The following is a description of a gene set: from publication Ventre E, Brinza L, Schicklin S, Mafille J, Coupet CA, Marçais A, Djebali S, Jubin V, Walzer T, Marvel J (PMID 22942430) studied in species Homo sapiens Effects of IL-4 on CD8 T cells functions are largely unknown. IL-4 induces survival and proliferation of CD8 T cells, but several studies suggest that IL-4 could also affect several functions of CD8 T cells such as cytotoxicity. Our team has shown that IL-4 repress the expression of Ccl5 in vitro. To define more precisely the impact of IL-4 on CD8 T cells, we performed a whole genome expression microarray analysis of naive and memory CD8 T cells cultured in presence or absence of IL-4. This approach allowed us to define the IL4-gene-expression signature on CD8 T cells. Genes down-regulated in comparison of memory CD8 T cells versus those treated with IL4. Human Gene Set: GSE32423_CTRL_VS_IL4_MEMORY_CD8_TCELL_DN, and this is the list of marker genes: PIP5K1C, SLC35B2, PSME2, SLC12A4, PPM1E, SARS1, NDUFB10, AARS1, CCT8L2, PHLPP1, ELMO3, SLC35F1, SYT7, TPPP3, GLIS3, RAB13, NGFR, ARHGAP26, EN2, MTFR2, UBL4A, BCAP31, MRPS25, COPS6, GGACT, GBP4, BRS3, PDE6C, PRKD1, MAGEA11, C1orf56, FPR2, IRGM, NSMCE1, ARHGEF28, RIGI, PINX1, MARCHF2, WNT16, CHCHD4, IL15RA, EIPR1, NDST1, ACAT2, PPIH, NIN (NCBI Gene Id 57681), MEI1, SLC12A1, PSMF1, NPC2, SMC1A, MAP3K8, SFMBT1, CLN5, DHX58, MBNL2, FBXW12, NAGPA, RNASEK, SLC25A13, ANGPTL2, SLC16A7, VPS4A, SEC24A, FAM229B, PLEKHH1, NUBP2, TAPBP, SLC4A1AP, ETNK1, P2RX5, SNRPN, SLIRP, IKZF3, POLM, SLC7A13, NAALADL1, PRSS23, ZNHIT1, AK2, MBD6, SPRR2A, GNMT, HLA-DMA, SYCE2, CXorf58, STAT2, USP7, TRAPPC3, SSPN, PCOLCE2 (procollagen C-endopeptidase enhancer 2), UBA1, PANX1, REX1BD, LRRIQ4, IFT27, HSD17B7, BCL2, SULF2, SLC26A6, PPP3CC, TADA1, AFG2B, ADCY10, MVD, RAB19, BAK1, PARP9, DHODH, AQP9, F2, ZNF141, G0S2, ACTN2, PSMD14, IRAG2, CTSZ, SLC39A6, TEX22, MAMLD1, TNNI3, PRDM1, LRRC2, MRPS15, LRTM2, FSCN2, KAZN, BCS1L, SLC25A23, KHDRBS2, MRPL30 (NCBI Gene Id 64985, mitochondrial ribosomal protein L30), DENND2A, SKIDA1, MORN3, DDC, KDF1, POLR2B, LRRC47, UBA7, S100A13, MSMO1, DGKI, UST, MRPS24, NDUFA7, RELT (NCBI Gene Id 84957), ZFP1, DENND5A, IQGAP1, MTUS2, MYBPC1, TBCK, COL10A1 (NCBI Gene Id 93042), IFI35, TCP1, ADH4, RNF169, YARS1, AVEN, MEP1B, TNFSF14, DCAF4, EPHA3, POLE2, RAP1GDS1, LMAN2L, HOXB4, MOV10, CCND3, TKT, GLIPR2, ATG9A, EOMES, USP18, SLC6A5, OAS1, FDPS, C5orf52, CLCN5, OLA1, DBNL, NDUFS5, TAFA3, FOXN3, FKBP1A, ARAP2, HJURP, LDHA, MED29, PFDN6, MTCH1, CLIC5 (NCBI Gene Id 53405), RMC1, TINF2, ADGRA2, NIPA1, ERG28, CYP19A1, HLA-E, XYLB